The following is a description of a gene set: The aim of this study was to identify genes regulated by IL-12, IL-18 and IFN-alpha during early differentiation of human Th1 cells studied in species Homo sapiens Human Gene Set: GSE20198_UNTREATED_VS_IL12_TREATED_ACT_CD4_TCELL_DN Genes down-regulated in the activated CD4 T cells (48h): control versus IL-12. from publication Filén S, Ylikoski E, Tripathi S, West A, Björkman M, Nyström J, Ahlfors H, Coffey E, Rao KV, Rasool O, Lahesmaa R (PMID 20304822), and this is the list of marker genes: ATP5PB, XYLT2, PELP1, TTC12, PTTG1IP, MAPKAP1, SKA2, FAM229A, SLC7A4, SLC37A2, CNTROB, TRIM45, PORCN, CRYBG1, SLFN12, PTPN21, ALDH18A1, C19orf44, KDM4A (lysine demethylase 4A), PBK, DDRGK1, MTR, MCTP1, NAAA, DIAPH2, PLEKHA2, SLC35C2, TRPM4, GNA11, TMEM223, DLGAP4, FOXD2, BCR, FEZ2, OXCT1, ZNF507, MEF2C, SFXN2, GUCD1, GBP7, PENK, ERMARD, GNGT2, UNC5CL, ARRB1, PAG1, ITGB3, VPS13B, ERMP1, TNFRSF1A, GAA, NFYA, PLEKHA5, ATRNL1, KIDINS220, SLC5A1, S100A13, CHST11, EPHA5, HERC2, RBL2, L1CAM, FKBP9, CXorf38, ENSG00000267882, MMAA, B3GNTL1, SLC22A15, CASKIN2, DHX30, MLH1, ING1, HLCS, PITPNM2, ST8SIA2, FN1, ZPBP2, GOLGA1, UGCG, YME1L1, TANGO6, BTBD8, DHDH, LRTM2 (leucine rich repeats and transmembrane domains 2), CXXC4, NEO1, EPC2, DSE, GALNT4, STAG2, GSS, CNR2, PHACTR4, NFIC, ODF2L, HLTF, SLC25A24, ACTG2, SYNJ2BP, IGSF9, CCNJ, MAP2K7, SLC2A8, DNAJC3, TBX6, ELFN2, C12orf75, DNAAF9, HP1BP3, PIK3CD, ATN1, HIP1, DRG1, CLCN5, ENDOU, TLR2 (toll like receptor 2), SLC39A3, ADAMTSL4, TSPAN5, POT1, SPN, ATP9B, ZXDC, SLC32A1, MVK, H3-5, RHOBTB1, ABL2, HEPACAM2 (HEPACAM family member 2), ITPK1, ATF7IP, DAAM2, PPM1D, MCU, NUDT7, UQCRB (NCBI Gene Id 7381), ADGRE1, TRAF3, SFT2D2, LMO2, RAD51C, IPCEF1, RBM42 (NCBI Gene Id 79171), TTF2, RIPOR1, TMEM241, CIMIP7, CCDC87, AAMDC, ADCY5, ZNF646, LCLAT1, CCNE1, EHF, MATK, MEN1, CYS1, GKAP1, CREBL2, GBA2, CCDC88B, KBTBD7, VAV2, TUBG1, KCTD20, GRAMD1C, VAMP4, CCR10, HTRA1, ZNF383, NR3C2, PAK4 (p21 (RAC1) activated kinase 4), USP47, PRKRA, GRHPR, ELMOD2, MCMBP, P2RY13, FBXW4 (F-box and WD repeat domain containing 4), TNRC6C, TOPBP1 (DNA topoisomerase II binding protein 1), UBL7, CAPN5, CCPG1, ALG2, ENOX2, TRIM68, SUPT3H, PAQR8, RPS8, ITFG2, KLHDC10, SMG9, DCK, LANCL1, DRG2 (NCBI Gene Id 1819), SPACA4, KLRG1, PRELID2, DYRK2